The following is a description of a gene set: studied in species Homo sapiens Human Gene Set: GOBP_REGULATION_OF_CAVEOLIN_MEDIATED_ENDOCYTOSIS Any process that modulates the frequency, rate or extent of caveolin-mediated endocytosis., and this is the list of marker genes: CLN3, SRC, ITSN1, CAV3, PROM2, NEDD4L, UNC119